Given this list of marker genes KCNH1, BMPR1B, BMP2, GDF5, CANT1, CHST11, DDR2, here is a description of the gene set: Triangular shaped phalanges of the hand species: Homo sapiens Human Gene Set: HP_TRIANGULAR_SHAPED_PHALANGES_OF_THE_HAND